Given this list of marker genes Prdm16, Pabpn1, Prkn, Clu, Arih1, Dvl2, Urb2, Hspb7, Ubqln1, Agl, Zbtb14, Mapt, Fgr, Nefm, Picalm, Bag5, Sfmbt2, Prkcq, Eef2, Gpx1, Nup98, Snca, Hap1, Klhl14, Htt, Atxn1, Psmc5, Pold1, Hsp90ab1, Hoxd3 (NCBI Gene Id 15434), Ifi204, Fbxo7, Edem1, Sncb, Eps15, Psmc6, Nub1, Atf4, Rnf32, Nbn (nibrin), Klf8, Slc2a3, Nup153, Trim50, Nefh, Rangap1, Cabin1, Iapp, Hspa1b, Rad50, Card14, Slf1, Hoxc9, Psen1, Ranbp2, Wdfy3, Nxf1, Xrn2, Dnajb2, Miox, Trim37, Hspa1a, Stub1, Gys1, Keap1, Tdp2, Herpud1, Ubd, Sqstm1, Hdac6, Psap, Mt3, Stradb, Psmc4, Rad18, Prnp, Tpr, Atxn3, here is a description of the gene set: A discrete intracellular part formed of aggregated molecules such as proteins or other biopolymers. Mouse Gene Set: GOCC_INCLUSION_BODY studied in species Mus musculus